Given this list of marker genes PRAP1, XRCC6, KARS1, CCND1, TP53, IKBIP, XRRA1, GATA3, LCN10 (lipocalin 10), NIPBL, BRCA2, ERCC8, BRCC3, SFRP2, TP53BP1, THBD, XRCC4, ATM, ERCC1, LCN2, ERCC6 (ERCC excision repair 6, chromatin remodeling factor), NUCKS1, CCND2, LIG4, CASP3, BLM, MSH2, SFRP1, XRCC2, RAD51, here is a description of the gene set: Human Gene Set: GOBP_RESPONSE_TO_X_RAY Any process that results in a change in state or activity of a cell or an organism (in terms of movement, secretion, enzyme production, gene expression, etc.) as a result of X-ray radiation. An X-ray is a form of electromagnetic radiation with a wavelength in the range of 10 nanometers to 100 picometers (corresponding to frequencies in the range 30 PHz to 3 EHz). species: Homo sapiens